The following is a description of a gene set: species: Homo sapiens Human Gene Set: HP_SYNOSTOSIS_OF_JOINTS Synostosis of joints The abnormal fusion of neighboring bones across a joint., and this is the list of marker genes: FGFR2, PCNT, FGF9, SOX5, CHST3, CHRNG, SALL1, RAF1 (NCBI Gene Id 5894), RASA2, MACROH2A1, EVC, HGD, ELN, PTH1R, FKBP6, MAF, TBX15, AFF4 (NCBI Gene Id 27125), BHLHA9, NADSYN1, FKRP, CBL, TBX4, FLNA, HOXA13, PTCH2, LIMK1, MASP1, POLR1D, GTF2IRD2 (GTF2I repeat domain containing 2), MESP2, SF3B4, FANCI, ZIC3, NOTCH3, TAF6, SMAD4, FLNB, OFD1, STX1A, CLIP2, ROR2, DNAL4, AEBP1, NOG, FGFRL1, ASXL2, SOX2, HDAC8, PLOD2, BRPF1, VPS37D, TBX6, TMCO1, HES7, SMOC1, FUZ, ESCO2, ACVR1, NTN1, SMC3, FBLN1, RECQL4, GLI1, ASH1L, BMPR1B, BICRA, WNT7A, RIT1, PUF60, DCC, MKKS, FGFR3, NSD2, IHH, LZTR1, COL27A1, METTL27, PRKACB, TFAP2B, EVC2, COLEC10, MYH3, DYNC2LI1, SOS1, EIF4A3 (eukaryotic translation initiation factor 4A3), BPNT2, SETBP1, ATP7A, POR, GDF3, FGFR1, BCOR, PTCH1, CHSY1, DNAJC30, CHN1, GDF6, FGD1, PTPN11, KAT6B, SALL4 (spalt like transcription factor 4), RNU12 (RNA, U12 small nuclear), MECOM, PTDSS1 (phosphatidylserine synthase 1), CHD4, UBAP2L, GTF2IRD1, KRAS, SMC1A, SMAD6 (SMAD family member 6), RPL26, NXN, B3GAT3, SUFU, COLEC11, GTF2I, TPM2, GPC3, DONSON, B4GALT7, DLL3, TNNT3, HOXA11, BMPER, TMEM270 (NCBI Gene Id 135886), DHODH, RAD21, PITX1 (paired like homeodomain 1), TBX5, TFAP2A, MAP3K20, ANAPC1, SLC26A2, ABCC6, VANGL1, ENPP1, GDF5, PRKACA, BUD23, B3GALT6, MRAS, XYLT1, LMBR1, APC, CANT1, MEOX1, EIF4H, TWIST1, TNNI2, SPRED2 (sprouty related EVH1 domain containing 2), FGF16, RRAS, LRP4, GSC, PIEZO2, NRAS, CHRNA1, LETM1, CPLX1, MLXIPL, NIPBL, SOS2, IL1RN, RIPK4, PAX3, KANSL1, SIX6, RBM8A, NCF1, CHRND, SF3B2, MAP3K7, MYO18B, PQBP1, CTBP1, CYP26B1, NALCN, DKK1, CDH11, MAFB (MAF bZIP transcription factor B), ANKRD11, NONO, SHH, TCF12 (transcription factor 12), FN1, CSGALNACT1, TBX22, RFC2, BAZ1B, RAD51, HOXD13, GPC4, RRAS2, ZIC1, TBL2, WBP11, GLI3, BRD4, COL2A1 (collagen type II alpha 1 chain)